Given this list of marker genes TRAPPC2B, MINDY2, CEP120, FAHD2A, RAMP1, FES, ZKSCAN3, UBR2, GANC, F9, EZH1, NFKBIE, ARL4A, FRAT2, DUSP6, HJURP, SNAPIN, CREB1, SLC12A3, DESI1, NUAK1, PAIP2, MINDY1, SLC25A35, DCLRE1C, TFDP2, HIPK3, GSE1, ACAP1, PCMTD2, PDIK1L, RPS6KA5, GMFG, LASP1, NLRX1, RESF1, FAM76B, PDE1B, PTPN22, STAG2, GPR19, TEC, TBXA2R, PHACTR4, PRR14L, CERS5, PIF1, HEYL, OAZ2, BCL2L2, CASS4 (NCBI Gene Id 57091), PHKA2, RNF169, MTCP1, BCKDHA, PAM16, SGSH, ST3GAL6, OGT, RAI1, SNX30, ITGA9, PANK4, USP33, SLC66A2, PARP4, LITAF, SRGAP3, ZCCHC2, RNF145, PNISR, APOLD1, EDARADD, NCAPD2, MAP7, RMND5B (required for meiotic nuclear division 5 homolog B), NRXN2, DENND5B, UNKL, CENPE, CFLAR, PDE3B, CDK5R1, TP53INP2, CNOT6, CD82, ENSG00000267882, TUG1, RAB3GAP1, PRSS23, SS18, SPO11, ATRX, PLEKHG5, BCR, ZFAND6, ING4 (inhibitor of growth family member 4), C19orf38, STK38L, NCOA2, BACH2, KBTBD2, TUT4 (NCBI Gene Id 23318), PPP1R13B, HECTD1 (HECT domain E3 ubiquitin protein ligase 1), PRDM1, SMAD5, ELMOD2, KATNAL1, TTBK2, MBD6, TRIB2, TSPAN13, SRR, CCDC82, RNASET2, SIGIRR, EPHX1, RAB43, TNFAIP3, CMIP, CCNG2, SPTBN1, TIA1, HDAC8, CDKN2C, RNF146, JMJD1C, LCK, CEP89, YPEL5, SLAMF7, MOB4 (NCBI Gene Id 96815), SSH2, FAM20B, CEP97, SIPA1L2, COLCA1, ACP5, CHRNB1, CYTH1, TNRC6C, C2orf68, ABI3, ANLN, MON2, FBXL12, ZNF22, SHCBP1, ASAH2, MKRN1, SMC5, NCF2, SLAIN1, ZC3H7A, PHF13, ZBTB34, TMEM80, CLIC1, NYX, COA6, CENPF, TTC14, UBE2J1, GIT2, MARF1, NIPBL, CWC22, NUMA1, FAM13B, MSH5, LEF1, SLX4, RNF111, KMT5B, ZFAND5, CD1D, IRGQ, SLC25A51, JAK1, PRMT9, STX16, GSKIP, DNAJC21, MBD1, LZTS3, CACNA1B, SPSB2, SUPT20H, ZFC3H1 (zinc finger C3H1-type containing), PRUNE1, SPC25, KLHL24, SNX33, NFATC1, RICTOR (RPTOR independent companion of MTOR complex 2), ZNF518A, HIBADH, SMAD3, here is a description of the gene set: Genes up-regulated in liver: IFNG knockout versus wildtype. Human Gene Set: GSE369_IFNG_KO_VS_WT_LIVER_UP Changes in mouse liver mRNA profiles following intraperitoneal cytokine injection. Either interferon-gamma-/-, albumin-cre(-) Socs3(w/fl) mice, or albumin-cre(+) Socs3(-/fl) mice were injected with either phosphate-buffered saline, interferon-gamma, or interfeukin-6, and livers taken after 4h. studied in species Homo sapiens from publication Croker BA, Krebs DL, Zhang JG, Wormald S, Willson TA, Stanley EG, Robb L, Greenhalgh CJ, Förster I, Clausen BE, Nicola NA, Metcalf D, Hilton DJ, Roberts AW, Alexander WS (PMID 12754505)